Given this list of marker genes Tnfaip3, Tlr4, Slc46a2, Slc15a4, Peli3, here is a description of the gene set: Mouse Gene Set: GOBP_REGULATION_OF_NUCLEOTIDE_BINDING_OLIGOMERIZATION_DOMAIN_CONTAINING_1_SIGNALING_PATHWAY Any process that modulates the frequency, rate, or extent of the nucleotide-binding oligomerization domain containing 1 (NOD1) pathway. species: Mus musculus